The following is a description of a gene set: Genes predicted to be targets of miRBase v22 microRNA mmu_miR_6945_3p in miRDB v6.0 with MirTarget v4 prediction scores > 80 (high confidence targets). from publication Chen Y, Wang X (PMID 31504780) studied in species Mus musculus Mouse Gene Set: MIR_6945_3P, and this is the list of marker genes: Itga6, Palld, Ocrl, Tab3, Disp3, Rab11fip4, Ncam1, Fadd, Ubash3b, Otop3, Luzp1, Pfn2, Sspn, Saysd1, Mtcl1, Rab39, Zic3, Tbx4, C2cd4c, Kcna5, Farp2, Zfp383, Cks2, Pus7, Eaf1, Dio1, Zbtb26, Zfp729a, Acvr2b, Glis2, Atf7, Ackr2, Khdrbs1, Dlg5, Arrdc3, Ppm1b, Ankrd44, Ubac2, Elovl6, Mlycd, Dmc1, Tmem38a, Fmnl2, Plin2, Sult5a1 (sulfotransferase family 5A, member 1), Cstf1, Acsl3, Senp1, Fgf14, Aipl1, Il7r, Rxfp2, Npr3, Ranbp6, Gm16130, Dnmt3b, Vangl1, Dyrk2, Dr1, Fen1, Itgam, Trak2, Fbxl18, Agbl3, Dpy19l1, Carhsp1, Il2, Onecut2, Slc16a4, Smim15, Il20rb, Ube2e3, Cxcl15, Zbtb4, Alppl2, Edem3, Lrrc1, Ywhab, Ap1s3, Ddx6, Dhcr24, Nap1l5, Rnf225, Ap3m1, Ttc24, Atp6v0e2, Lpar1, Mocs2, Dnajb2, Pip4k2b, Tex19.1, Lin28b, Map3k3, Oprk1, Zfp449, Chrna3, Rorc, Treh, Gal3st2, Pip4p2, Acnat1, Or51e1, Rho, Ano3, Gmcl1, Nid1, Wipf3